The following is a description of a gene set: Human Gene Set: MIR3136_3P Genes predicted to be targets of miRBase v22 microRNA hsa-miR-3136-3p in miRDB v6.0 with MirTarget v4 prediction scores > 80 (high confidence targets). species: Homo sapiens from publication Chen Y, Wang X (PMID 31504780), and this is the list of marker genes: EIF2A, CREBZF, LRRC55, RNF121, GTPBP10, MAP3K19, KIF7, SYCE2, CYSLTR1, MXI1, MND1 (NCBI Gene Id 84057), RAVER1, CHD3, SSH2, CPT1A, MFHAS1, CMTR1, TLE1, CLEC12A (NCBI Gene Id 160364), IL31RA, STXBP5L, DCP1A, PFN1, AP1G1, MFSD8, LDB1, AJAP1, UTP3, UVRAG, FAM161B, DIP2B, RNF38, SWT1, TBCK, NFKBID, TNPO2, C11orf87 (chromosome 11 open reading frame 87), NFASC, LRTM2, TCF12, MEIS2, SMARCA1, SPCS2, SH3PXD2A, ZNF746 (zinc finger protein 746), HMGB1, PGAP2, SUMO3, ANP32A (NCBI Gene Id 8125), PLOD2, CYTH4, SRSF2, KCNMA1, MSANTD2, NEK7, LRRC41, RNF7, STAB1, PATJ, PEX5L, KDM2A, HKDC1, SMARCD1